Given this list of marker genes Bpnt1, Inpp5j, Inpp5k, Minpp1, Inpp5d, Inpp4b, Inpp5b, Pten, Mtmr7, Inppl1, Inpp5a, Impa1, Synj2, Impa2, Inpp1, Inpp5e, Synj1, Inpp4a, Ocrl, Inpp5f, here is a description of the gene set: Catalysis of the reaction: inositol phosphate(n) + H2O = inositol phosphate(n-1) + phosphate. This reaction is the removal of a phosphate group from an inositol phosphate. studied in species Mus musculus Mouse Gene Set: GOMF_INOSITOL_PHOSPHATE_PHOSPHATASE_ACTIVITY